The following is a description of a gene set: Absence or underdevelopment of the patella. species: Homo sapiens Aplasia/Hypoplasia of the patella Human Gene Set: HP_APLASIA_HYPOPLASIA_OF_THE_PATELLA, and this is the list of marker genes: ORC1, SHOX, CHRNG, PITX1, LMX1B, CDT1, GMNN, PRMT7, GJB6, DONSON, ORC6, ANAPC1, KAT6B, FKBP10, CDC6 (cell division cycle 6), ZSWIM6, GJB2, WNT7A, ARID1B, RECQL4, ORC4, LMBR1, RBM8A, SOX9, TBX4, GDF5, BHLHA9, STXBP1 (NCBI Gene Id 6812), UBR7, CDC45, CRELD1, ESCO2, SHH